The following is a description of a gene set: Mouse Gene Set: GOBP_PYRIMIDINE_RIBONUCLEOSIDE_MONOPHOSPHATE_BIOSYNTHETIC_PROCESS studied in species Mus musculus The chemical reactions and pathways resulting in the formation of pyrimidine ribonucleoside monophosphate, a compound consisting of a pyrimidine base linked to a ribose sugar esterified with phosphate on the sugar., and this is the list of marker genes: Dck, Dhodh, Upp2, Cad, Uck2, Umps, Uckl1, Uck1, Uprt, Cda, Upp1